The following is a description of a gene set: Mouse Gene Set: MIR_6715_5P studied in species Mus musculus from publication Chen Y, Wang X (PMID 31504780) Genes predicted to be targets of miRBase v22 microRNA mmu_miR_6715_5p in miRDB v6.0 with MirTarget v4 prediction scores > 80 (high confidence targets)., and this is the list of marker genes: Rnf146 (NCBI Gene Id 68031), Dnm2, Fat1, Ube4b, Plxnc1, Rad21, Pcdh7 (protocadherin 7), Iqce, Jazf1, Ppp4r2, Mtss1, Zfp773, Sbf2, Prkcz, Baz1a, Tardbp (NCBI Gene Id 97174), Esyt2, Reep3, Lancl2, Dlst, Adissp (NCBI Gene Id 67326), Tmem248, Ikbkg, Cd79b, Klrc1, Scn2a, Kcne4, Slc8a1, Akip1, Ahcyl2, Irf1, Src, Tnpo3, Zfand5, Prlr, Hey2, Kras, Slc25a46, Taok3, Srpra, Mcat, Zeb1, Ark2c, Tdrp, Mms19, Nphp3, Tln1, Fbxo9, Golph3, Myrf, Jph3, Esr1, Arl5a, Ergic2, Myo18a, Cyb561d1, Creb5, Jpt2, Nr2f2, Kif16b, Anxa10, Kcnh8, Relt, Tcte1, Myorg, Kcnd3, Prx, Borcs7, Togaram1, Dvl2, Tom1l1, Stxbp4, Tpk1, Lrch2, Map2, App, Tmem215, Naa20, Csde1, Sox8, Mindy2, Rftn1, Ablim3, Rabgef1, Ptk7, Mlxip, Cast, Btbd7, Zfp608, Grk6, Kctd10, Cep164, Zfp324, Akap6, Unc119b, Rab33a, Cacna1b, Ube2k, Atg4a, Mapkapk3, Etf1, Appl2, Msl3, Slco2b1, Stk19, Pafah1b1, Cttnbp2nl, Htr7, Dcbld2, Sema4f, Jarid2 (NCBI Gene Id 97879), Cntnap1 (contactin associated protein-like 1), Qrich1, Kctd6, Npy1r, Sipa1l2 (NCBI Gene Id 277957), Rmnd5a, Podxl, Vwa5b2, Ints3, Mlec, Slc25a42, Nploc4, Awat2, Grk2 (G protein-coupled receptor kinase 2), Epha6 (Eph receptor A6), Ppm1g, Tent5a, Zbtb22, Flvcr1, Uhrf2, Mgat4b (mannoside acetylglucosaminyltransferase 4, isoenzyme B), Prkar2a, Stk39, Foxo1, Slc25a25, Tnrc6b, Atp6v0e, Reep1, Zdhhc17, Mapk8ip2, Srebf2, Trio, Rfx3, Eif4h, Seh1l, Zfp352, Erf, Icos, Zbtb40, Ldlr, Ino80d, Atxn7, Acvr1b, Dpf2, Atp5mc1, Snx30, Tmem250, Rsbn1l, Actr1b, Mypop, Scn3a, Specc1l, Gm10375, Camk2b, Als2cl, Tmem214, Csnk1g3, Otud7a, Ski, Zmym3, Gldc, Rhob